Given this list of marker genes LEP, E2F1, CHST11, MMP12, PTGS2, NOS1, RHOA, OMG, PTPRA, PPP3CA, RHOB, CASP3, KLK8, COL4A1, AIF1, CDK2, PRB1, FKBP1A, RAC1, EGFR, RHOC, IL6, NTN1, IL1B, TNFSF13B, TLR4, BDNF, RB1, SLIT2, FOS, PLA2G6, GDNF, PLXNA2, ACAN (aggrecan), CXCL8, TNFSF13, CCL2, RGMA, MYC, CDK4, PRB2, IL4, MBP, IL2, MAG, GFAP, TACR1, GRIN1, LGALS3, E2F5, MIF (macrophage migration inhibitory factor), AQP1, MMP9 (matrix metallopeptidase 9), RTN4R, ICAM1, NR4A1, CDKN1B, PRKCA, ROCK2, MAPK3, MIR23B, EGR1, CDC42, GJA1, CCNG1, SELP, TNF, AQP4, BTG2, SEMA6A, SLIT1, FCGR2A, ROS1, MAPK1, EFNB2, XYLT1, IL1R1, PDYN (NCBI Gene Id 5173), NOS2, IL1A, IFNG, VIM, CCR2 (C-C motif chemokine receptor 2), GADD45A, C1QB, GAP43, C5, COL2A1, TGFB1, NGFR, CCND1, SOX9, LILRB3, LTB, PTPRZ1, CD47, LTB4R, ZFP36, CXCL2, ARG1, PLA2G5, CDK1, CSPG4, ANXA1, APEX1, CXCL10, SLIT3, NCAN, BCAN, CXCL1, NOX4, VCAN, PLA2G2A, RTN4, EPHA4, TP53, FOXO3, here is a description of the gene set: Spinal cord injury studied in species Homo sapiens Human Gene Set: WP_SPINAL_CORD_INJURY